The following is a description of a gene set: The chemical reactions and pathways resulting in the biosynthesis of retinoic acid, one of the three components that makes up vitamin A. Mouse Gene Set: GOBP_RETINOIC_ACID_BIOSYNTHETIC_PROCESS studied in species Mus musculus, and this is the list of marker genes: Aldh1a1, Aldh8a1, Rdh9, Akr1c18, Rbp1, Rdh1, Aldh1a3, Rdh16, Rdh19, Dhrs9, Prmt3, Rdh16f2, Cyp1a1, Aldh1a2, Rdh10